Given this list of marker genes AARS1, LOXL3, CTSB, DMPK, MTCP1, B2M, PCBD2, FAM3C, RSPO2, NUDT19, CCDC167, ADCY3, AGRN, FAM111A, FAM83G, CANT1 (NCBI Gene Id 619513), C11orf24, NUP205, PTH1R, RHOU, BRCA2, RTL3, CHST14, AHSA1, KCTD8 (potassium channel tetramerization domain containing 8), NUDT18, SLC11A2, HLA-E, ZDHHC5, DNAJC2, CD86, CDKN1C, F9, SPRY2, LMNB2, DNAJC15, NTAN1, ZRANB3, IFI44, CFB, EXOSC8, CST7, BZW2, DNMT1, MRAP, PPA1, PAWR, ESYT3, MMP9, ZDHHC4, TSPAN3, BASP1, EVL, GJC1, NUP107, PTTG1, TPRA1, HLA-C, CD74 (NCBI Gene Id 972), HLA-G, ANXA11, LRTM2, MAP4K3, DUSP1, COX5A, CLCN7, LYAR, HBB, GPR162, ENTPD6, NR1H3, METRNL, CHD1L, CLUH, GNAS, PKP4, PPT2, ARPC2, GEMIN6, AIMP2, CP, EXOSC1, DIO2, PITPNM1, SPIC, HGH1, GALNS, ALKBH3, ANXA4, IARS1, CENPT, DDX24, ODC1, COQ2, DIXDC1, INTS2, ACER3, POR, MTHFD2, SERF2, TMEM230, CA9, CAV3, TIPIN, CCDC137, PCNA, COX6A2, PLD3, COX10, RAI1, ATF4, SMYD4, BCAN, CLIP3, TONSL, CCL5, FCRL1, ANXA2, ARPC5L, CSE1L, AZIN1, IRAK1, SERTAD1, ARMC7, CD68, TTC39C, CEP41, CRLF2, KAT2A, CBX4, PPFIBP2, POLR2F, CCND1, PRRX2, HLA-DRB1, INPP5B, JADE2, SYN1, TMEM80, BOLA3, IL18BP, EEFSEC, TMX2, RGS18, IRF2BP1, HLA-B, PSMD14, ECHDC2, ANKRD9, CKB, CAMK2N2, TRMT61A, TSR2, DDX51, MCM5, RPS6KA2, CEND1, SMC2, KRI1, SFRP5, NR2F2, GSDME, GASK1B, TRIAP1 (TP53 regulated inhibitor of apoptosis 1), DONSON, MESD, SERPINB9, CPQ, UNC5B, MOCS2, DDIT3, DDX21 (NCBI Gene Id 9188), C1orf52, ELL2, ATF5, DCX, C3, CNKSR1, HSD17B12, ESRRG (estrogen related receptor gamma), PDZD4, LONRF3, CHCHD1, ZNF513, SFXN2, IGF2BP2, HLA-DQA1, DGKB, GAR1 (GAR1 ribonucleoprotein), LGALS3BP, IL2RG, POLD1, LENG1, ANXA1, APOC3, PPIA, FANCC, KITLG, C1QC, here is a description of the gene set: Genes up-regulated in lymph node CD4 T cells: scurfy (non-functional form of FOXP3) versus scurfy and IL2 knockout. The goal of the study was to identify the genes which are regulated by Interleukin-2 in the CD4+ T cells of the scurfy mice during regulatory T-cell deficiency. Scurfy (Sf) mice bear a mutation in the forkhead box P3 (Foxp3) transcription factor, lack regulatory T-cells (Treg), develop multi-organ inflammation, and die prematurely. The major target organs affected are skin, lungs, and liver. Sf mice lacking the Il2 gene (Sf.Il2-/-), despite devoid of Treg, did not develop skin and lung inflammation, but the inflammation in liver, pancreas, submandibular gland and colon remained. Genome-wide microarray analysis revealed hundreds of genes were differentially regulated among Sf, Sf.Il2-/-, and B6 CD4+ T-cells but the most changes were those encoding receptors for trafficking/chemotaxis/retention and lymphokines. Our study suggests that IL-2 controls the skin and lung inflammation in Sf mice in an apparent \organ-specific\ manner through two novel mechanisms: by regulating the expression of genes encoding receptors for T-cell trafficking/chemotaxis/retention and by regulating Th2 cell expansion and lymphokine production. Thus, IL-2 is a master regulator for multi-organ inflammation and an underlying etiological factor for various diseases associated with skin and lung inflammation. Methods: CD4+ T cells were purified by Fluorescence Assisted Cell Sorting from the peripheral lymph nodes of (A) three individual Scurfy (Sf; B6.Cg-Foxp3sf/J) male mice, (B) three individual Sf.Il2-/- male mice (Scurfy mice carrying a null Interleukin (IL)-2 gene (B6.129P2-Il2tm1Hor/J)) and (C) a pooled sample of lymph nodes from two B6 (C57BL/6J) mice. All the mice were 3 weeks old. Total RNA was prepared using RNeasy mini kit (Qiagen). RNA samples were converted to cRNA, labeled and hybridized to Affymetrix Mouse 430_2 chips (Mouse Genome 430 2.0 Array, Affymetrix, Santa Clara, CA) at the University of Virginia DNA Sciences Core Facility. from publication Sharma R, Sharma PR, Kim YC, Leitinger N, Lee JK, Fu SM, Ju ST (PMID 21169543) studied in species Homo sapiens Human Gene Set: GSE23398_WT_VS_IL2_KO_CD4_TCELL_SCURFY_MOUSE_UP